Given this list of marker genes Pid1, Dhrs7c, Slc27a4, Ins2, Slc2a12, Mef2a, Irs1, Slc45a2, Grb10, Slc5a3, Erbb3, Enpp1, Sirt6, Sorbs1, Nr4a3, Appl2, Sort1, Opn3, Osbpl8, Yes1, Slc2a7, C1qtnf12, Erfe, Slc23a1, Gip, Septin7, Clip3, Pou4f2, Ahi1, Prkcd, Slc27a1, Gpc3, Rnasel, Selenon, Trarg1, Ak1, Slc2a1 (solute carrier family 2 (facilitated glucose transporter), member 1), Appl1, Drd1, Ptpn11, Hnf1a, Irs2, Slc2a3, Rps6kb1, Tsc2, Mapk14 (mitogen-activated protein kinase 14), Slc5a2, Acacb, Tert, Pea15a, Mfn2, Braf, Stxbp3, Slc2a10, Igf1, Slc2a5, Gsk3a, Rhoq (NCBI Gene Id 80836), Sh2b2, Il1b, Slc26a5, Fabp5, Prkca, Prkci (NCBI Gene Id 99620), Rasa1, Cd2ap, Slc5a1, Akt2 (NCBI Gene Id 76480), Klf15, Tnf, Trib3, C2cd5, Rab4b, Rap1a, Insr, Grk2, Rtn2, Ins1, Zdhhc7, Slc2a6, Gh, Stxbp4, Aoc3, Cers1, Ffar4 (NCBI Gene Id 209389), Fgf21, Ostn, Fgf15, Esr1, Ednra, Slc25a27, Repin1, Met, Slc2a2, Capn10, C3, Crebl2, Inpp5k, Prkcb, Slc2a4, Hk2, Smim43, Akt1, Sgcb, Myc, Oga, Tsc1, Erbb4, Edn1, Upk3b, Ctns, Slc2a8, Nfe2l2, Itln1, Adipoq, Slc23a2, Slc5a4b, Slc1a2, Aspscr1, Pth (parathyroid hormone), Ocln, Slc2a9, Sesn2, Adipor2, Slc5a10, Slc45a1, C1qtnf2, Lep, Slc5a4a, Ace, here is a description of the gene set: studied in species Mus musculus Mouse Gene Set: GOBP_MONOSACCHARIDE_TRANSMEMBRANE_TRANSPORT The process in which a monosaccharide is transported across a lipid bilayer, from one side of a membrane to the other. Monosaccharides are the simplest carbohydrates; they are polyhydric alcohols containing either an aldehyde or a keto group and between three to ten or more carbon atoms. They form the constitutional repeating units of oligo- and polysaccharides.